The following is a description of a gene set: Unlike other glycoproteins, correct folding of MHC class I molecules is not sufficient to trigger their exit from the ER, they exit only after peptide loading. Described here is the process of antigen presentation which consists of the folding, assembly, and peptide loading of MHC class I molecules. The newly synthesized MHC class I Heavy Chain (HC) is initially folded with the help of several chaperones (calnexin, BiP, ERp57) and then binds with Beta-2-microglobulin (B2M). This MHC:B2M heterodimer enters the peptide loading complex (PLC), a multiprotein complex that includes calreticulin, endoplasmic reticulum resident protein 57 (ERp57), transporter associated with antigen processing (TAP) and tapasin. Peptides generated from Ub-proteolysis are transported into the ER through TAP. These peptides are further trimmed by ER-associated aminopeptidase (ERAP) and loaded on to MHC class I molecules. Stable MHC class I trimers with high-affinity peptide are transported from the ER to the cell surface by the Golgi apparatus. Reactome Pathway: Antigen Presentation: Folding, assembly and peptide loading of class I MHC species: Homo sapiens part of: Class I MHC mediated antigen processing & presentation, and this is the list of marker genes: SAR1B, ERAP1, BCAP31, CALR, SEC31A, ATG14, CANX, ERAP2, PDIA3, HLA-A, HLA-F, B2M, HLA-G, 8, BECN1, SEC24B, PIK3R4, SEC24A, PIK3C3, HLA-H, SEC24D, TAPBP, HLA-B, SEC24C, HLA-E, TAP2, TAP1, HSPA5, SEC23A, SEC13, HLA-C